The following is a description of a gene set: The chemical reactions and pathways resulting in the formation of a cyclic nucleotide, a nucleotide in which the phosphate group is in diester linkage to two positions on the sugar residue. studied in species Homo sapiens Human Gene Set: GOBP_CYCLIC_NUCLEOTIDE_BIOSYNTHETIC_PROCESS, and this is the list of marker genes: ADCY9, ADCY3, GUCY2C, GUCY2F, NPR2, NPPC, GUCY1A2 (guanylate cyclase 1 soluble subunit alpha 2), ADCY4, ADCY5, GUCY1A1, ADCY8, ADCY7, NPPA, NPR1, ADCY1, GUCY2D, ADCY2, GUCY1B1, ADCY10, ADCY6, NPPB